Given this list of marker genes SRD5A1, KANK2, HIGD1A, JMY, UPP1, PIK3C3, SREBF1, COMT, TRIM24, RRAGB, MAP3K5, RXRB, XPR1, OGT, PRKAG2, GAS2L1, CASTOR1, INHBA, FOXO3, ATF4, PCK1, PLD1, PAK2, UCN3, FAM107A, PAK1, CASR, WIPI2, YWHAG, MIOS, KLF10, SLC7A5, GABARAPL2, RRAGA, ATXN3, MYH13, BECN2, HNRNPA1, HSPA8, SLC2A1, CDKN2B, INHBB, PHEX, MAPK3, EIF2AK4, KCNB1, PRKAB1, GCGR, MFSD2A, RPTOR, KAT2B, SLC34A1, FOLR2, ATF3, MLXIPL, PRKAB2, DRAM1, NFE2L2, FAS, PLIN2, ATG5, TNRC6A, WDR45B (WD repeat domain 45B), OTUD3, MED1, RPS6KB1, USP33, KPTN, PAK4, RALB, MIR125B1, FGF23, LAMP2, FADS1 (fatty acid desaturase 1), GABARAPL3, TBC1D7, EIF2AK2, CYP27B1, SNW1, NUAK2, SFRP1 (secreted frizzled related protein 1), PIM1, NUPR2, MTOR, IFI16, COL1A1, PPARA, STK24, RRAGD (Ras related GTP binding D), TP53, SMDT1, PPARD, TSC2, PAK3, TRIM32, RIPOR1, CARTPT, LEP, XBP1, EIF2S1, FLCN (folliculin), ASNS, SP1, EIF4G1, RRAGC, CAV1, GPRIN3, PIK3R4, GABARAP, MAPK1, UCN2, RNF152, PPM1D, SEH1L, ZFYVE1, MAP1LC3A, PDK4, KRT20, VPS41, TNC, SLC38A2, SEC13, ITFG2, DNAJC15, NCOA3, WRN, BHLHA15 (NCBI Gene Id 168620, basic helix-loop-helix family member a15), CREBBP, EP300, MAP1LC3B, SNAI2, MDM2, PRKAA1, USF1, CD68, FBXO22, PRKAG1, ATF2, SAR1A, CSNK1A1, NPRL2, YME1L1 (YME1 like 1 ATPase), BMPR2, PMAIP1, SLC38A3, AKR1C3, FOXO1, ALB, ATG7, CYP24A1, DSC2, WNT2B, ELAPOR1, FNIP1, KCNJ11, SESN1, GAS6, KAT5, GPR155 (NCBI Gene Id 151556), EHMT2, STK26, RXRA, ABCC8, MAT2A, MTMR3, WDR59, SLC39A5, SRF, ZC3H12A, HRK, SESN3, PRKAA2, PRKCH, PAK6, PENK, LARS1, FOXA3, LRRK2, SZT2, PAK5, LAMTOR1, RHEB, WDR45, CDKN1A, SUV39H1, MYBBP1A, GLUL, TFEB, WNT9B, SESN2, PIK3C2B, PRR5, FES, LCN2, CADPS2, NPRL3, POSTN, PRMT1, SH3GLB1, PRKD1, TTC5, PDK2, MYOD1, SP7 (NCBI Gene Id 121340), MLST8, MAP1LC3B2 (microtubule associated protein 1 light chain 3 beta 2), USF2, ULK1, FOS, SAR1B, MICU1, IMPACT, YWHAZ, BGLAP, TSC1, SREBF2, GBA1, NCOA1, RICTOR, WNT4, RNF167, MAPK8, GCN1, SAMTOR, AMBRA1, GABARAPL1, VDR, MAP1LC3C, CLEC16A, GDAP1, MAPKAP1, CPEB4, WDR24, CHKA, UCP2, SIRT1, ATG14, TBL2, SLC39A4, MCU, WIPI1, TNFRSF11A, KICS2, BCL2, BECN1, PLIN3, RRP8, MN1, HSPA5, LPL, FOLR1, PRKAG3, PCSK9, DEPDC5, EIF2AK3, PICK1, here is a description of the gene set: Human Gene Set: GOBP_CELLULAR_RESPONSE_TO_NUTRIENT_LEVELS species: Homo sapiens Any process that results in a change in state or activity of a cell (in terms of movement, secretion, enzyme production, gene expression, etc.) as a result of a stimulus reflecting the presence, absence, or concentration of nutrients.